Given this list of marker genes AKR1B1, PBXIP1, ALKAL1, AZGP1, IRAG2 (inositol 1,4,5-triphosphate receptor associated 2), KRT8, BIK, CLDN3 (claudin 3), SCNN1B, BSND, TPD52, SLC14A1, STAP1, QPCT, SMS, ATP6V0B, DMRT2, KRT18, SEMA3C (NCBI Gene Id 222200), GOLM1, RARRES2, ATP6V1G3, C15orf48, EPCAM, ASCL3, ATP6V1A, PCP4, CFTR, HES6, APLP2, CRTAC1, AVIL, FOXI1, CD24, ANXA4, RGS13, CLCNKB, RASSF6, CD9, KRT7, SC5D, GNG13, IGF1, LINC01187, TUBB2B, HEPACAM2, GNGT1, BMX, ENC1, MGST1, CLGN, FAM3B, TMEM61, here is a description of the gene set: species: Homo sapiens from publication Durante MA, Kurtenbach S, Sargi ZB, Harbour JW, Choi R, Kurtenbach S, Goss GM, Matsunami H, Goldstein BJ (PMID 32066986) Human Gene Set: DURANTE_ADULT_OLFACTORY_NEUROEPITHELIUM_OLFACTORY_MICROVILLAR_CELLS